The following is a description of a gene set: Monocyte-derived dendritic cells (DC) and macrophages (MΦ) generated in vitro from the same individual blood donors were exposed to five different pathogens, and gene expression profiles were assessed by microarray analysis. Responses to Mycobacterium tuberculosis and to phylogenetically distinct protozoan (Leishmania major, L. donovani, Toxoplasma gondii) and helminth (Brugia malayi) parasites were examined, each of which produces chronic infections in humans yet vary considerably in the nature of the immune responses they trigger. Genes up-regulated in comparison of macrophages exposed to L. major versus macrophages exposed to M. tuberculosis. Human Gene Set: GSE360_L_MAJOR_VS_M_TUBERCULOSIS_MAC_UP species: Homo sapiens from publication Chaussabel D, Semnani RT, McDowell MA, Sacks D, Sher A, Nutman TB (PMID 12663451), and this is the list of marker genes: SULT1B1, ZCCHC14, ADRA2C, SHC1 (SHC adaptor protein 1), MYBPC2, POLDIP3, EOLA2-DT, AMOT, TCF25, PRLR, MEF2C, CLIC2, MT1B, CDH1, KIF3C, CNN3, BRCA1, PMM1, ID4 (NCBI Gene Id 3400), KCNQ1, TRIM10, PLLP, NCAPD3, NUDT3, DBH, BMP3, UBN1, ATP6V1F, SVIL, PGLYRP1, ACTG2, PAX1, PON1, C1orf105, CPA3, ITGAX, MMRN1, ALPI, SOX15, DAPK2 (NCBI Gene Id 23604), IL1RN, RNFT2, ZG16, TNFAIP6, PLEKHA6, CYP2C8, PTPN1, SPAG6, PTPN4 (NCBI Gene Id 5775), PLK1, TP53BP2, POU2AF1, NPR1, EPB41, DUS4L (dihydrouridine synthase 4 like), SLC7A1, JMJD1C, TBC1D2B, GPRIN2, MPHOSPH10, AHNAK, KRT2, MYL4, CLIC5, PTPN21, GLA (galactosidase alpha), PLPP3, CSN2, GATC, ABTB2, AKR1C3, FSHB, DVL3, VPS52, DUSP5, JAK1, SYN3, NUP188, GFUS, IL12B, MKNK2, ACRV1, GNAO1, CA6, JAG1, VHL, POLR3C, TLN2, BRD2, ACOT11, COL17A1, MAPK8, MYOZ2, SYN2, CASP2, CIB2, MOK (NCBI Gene Id 5891), PSMD7, CENPA, REL, SKAP1, IRF5, ZPR1P1, LDB3, KRT4, CHEK1, IL4, MUC2, PPBPP2, H2BC12, CD84, VAC14, RBBP8, GAB1, TXNRD1, NOVA2, KIF5A, IGF1R, PLRG1, ZNF674, RUBCN, NMT2, AKR1B1, PABPC1, PPP1R2C, MFAP2, NUP58, LBX1, TRIM66, TAX1BP1, VAMP1, DNAH7, MISP (mitotic spindle positioning), SND1-IT1, MSC, LCAT, APOH, FUT5, SST, PRKN, GPR35, TACR2, ZC3H4, ISL1, TNFRSF4, IQCK, NCALD, NFKB1, PIAS1, SMG5, RORA, CAMKK2, WIPF1, CD83, COL13A1, ENOSF1, LPAR2, LYRM9, CAP2, DDX6, NUP214, HMGA1, CDV3, NAGPA, TH, INPP1, LEP, LAMP1, GATA6 (GATA binding protein 6), DCT, KCNH2, CDK5R2, RPS6KA1, RPL23AP53, RRAGB, ASS1, PXDC1 (PX domain containing 1), MAPKAPK5, CYLC1, TAF1, RPGRIP1, MKLN1, GRIK2, HHLA1, RBP3, MT1G, SPINK1, TRIAP1, LAMB3, TRAF5, SPRR2D, CCR7, DGCR5, IL3RA, S100B, FUT7